The following is a description of a gene set: species: Homo sapiens Human Gene Set: IK1_01 Genes having at least one occurrence of the motif NHNTGGGAATRCC in the regions spanning 4 kb centered on their transcription starting sites. This matches the transcription factor binding site V$IK1_01 (v7.4 TRANSFAC)., and this is the list of marker genes: ANKRD39, TEF, KGD4, JPT2, KIF12, ABR, WDR62, CDK6 (cyclin dependent kinase 6), PDE10A, CCDC91, SNCAIP (NCBI Gene Id 9627), VSX2, GSTT4, MCU, PSD, DHRS4, VAT1, PRKACA, LUC7L3, DDX5, RBM4, CXCL14, LCN10, NEK4, GRIN2B, TJAP1, GATAD1, POU3F3, RND1, KCNQ4, PNKD, FNBP1L, RNF43, MMP16, GNA11, SMYD2, KCNJ2, HID1, LUZP1, ASCL3, FOXD3, HOXC6, COL12A1, MKNK2, DCSTAMP, AAMP, C9orf43, ARPC2, SP6, HOXC11, FGF13, SGCD, TNNC2, NDUFAF3, DLX1, ABCA2, THAP8, ZPBP2, CLCN1, IL1RAPL1, PI16, GNB2, TES, SOBP, PLA2R1, PRMT1, FOXP1, CD86, ZBTB37, CRTAC1, YRDC, ARID1A, CDKN2C, TASL, SLITRK1, FILIP1, PARP8, NR3C2, CITED2, GP2, ZIC5, NCOA2, DLL4, TOP1, ACTN1, MRPS18B, ERC1, MSX1, CEP95, RNF128, LINC02908 (long intergenic non-protein coding RNA 2908), VARS2, ELMO3, R3HDM1, PIAS1, LTBP1, JUN, PPP2R5E, APOLD1, FGF17 (fibroblast growth factor 17), PATL1, BMP4, HMGA2, OR10A5, VPS53, ATP1A3, SALL1, MIR17HG, ARAP3, POLR2B, CHAD, APPL1, SAV1, LRMDA, KIRREL2, CD69, SMOC1, PURG, HOXB4, GNL3LP1, PPP1R10, GUCY1B1, BAZ2B, CLASRP, IL6, TINAG, ZC3H11A, BRCA1, GPM6A, IFNB1, ITPR1, ADGRB3, ZEB1, TMEM88, TBX19 (NCBI Gene Id 9095), ZIC4, PLPP3, BCKDK, CYP26A1, LRP1, NR4A3, ZNF687, TMEM94, NLK, EHF, TRPC4 (NCBI Gene Id 7223, transient receptor potential cation channel subfamily C member 4), RHBDF1, SHC3, CD93, PNLIPRP1, TMEM69, ITM2B, ABCC5, TUBGCP4, NR2F6, VGF, LIFR, SKIDA1, ADAMTSL5, ST13P4, HIVEP1, ACKR3, TBX20, DOC2A, BTF3P11, HOXB13, RNF213, HS3ST4, PROP1, ACVR2B, RELB (NCBI Gene Id 5971), ZFPM2, POLA1, KPNA3, MOB3C, TBXT, ELK4, CILP, TMEM95, MSI1, TNIP1, CCL20, PREX2, PTCH1, LRP2, MRTFA, POLR3B, ICAM1, RDH10, RBMS1, NDP, NFATC2IP, TFAP2A, TRPC1, HOXC5, LHX6, WWP2, TWIST1, ZSCAN29, SORBS3, COX18, KCNAB1, BCL3, DALRD3, TOR1AIP2, TNFSF15, FAM117A, TNFRSF21, ATP1B1, OTX1, RFX4, NKX2-1, LINC00670, CPSF7, DHRS4L2, SYCE1, ATXN7L1, ATP2B4, AHNAK, UBE2H, WRN, FBXO3, ZNF710, NAPB, LNX2, FOXO4, ELF5, SLC26A6, SOCS2, STARD13, NEK6, TGM3, SERBP1, SEMA6A, MED1, HCN3, PRDM1, ARHGAP5 (Rho GTPase activating protein 5), TNFSF18, NAPG, MEOX2, P2RX1, LRP2BP, NOA1, APBA1, FOSL2, VAMP3, NSD1, LAMA1, NNAT, RORA, ALKBH6, ZNRF1, EIF4ENIF1, SPEN, POLE3, SRSF7, STOML2, COBL, USP15, RRM1, RAB10, IRF2BPL, IL13RA1, SEMA3G, PCDH17, KRT36, C1orf122, MID2, PHLDB1, VSNL1, RARB, SP4, CFAP251, ADAMTS20, MYOCD, EPHB2, GADD45B, HOXC4, PACSIN2, NFKB2, FAM89A (NCBI Gene Id 375061)